The following is a description of a gene set: Human Gene Set: MORF_DDX11 Neighborhood of DDX11 species: Homo sapiens Neighborhood of DDX11 DEAD/H (Asp-Glu-Ala-Asp/His) box polypeptide 11 (CHL1-like helicase homolog, S. cerevisiae) in the MORF expression compendium, and this is the list of marker genes: IKBKG (NCBI Gene Id 8517), HTR4, ADAMTSL2, PAX8, PLIN3, IRF2BP1, TM4SF5, ALDOC, IRF2, SLC22A24, AMFR, CALCOCO1, F7, GALNT2, SLC12A4, NFRKB (NCBI Gene Id 94689), CSNK2A1, CLPX, HSF4, LSM12, PRSS16, SLC24A1, TEX28, ADAM15, IGSF9B, AQP5, EXTL3, SPTB, TCOF1, SLC30A3, DOK1, TTI1, ZNF592, CIZ1, TRA2A, NDST1 (NCBI Gene Id 3340), PMF1, PPIL2, PITPNM1, IGHMBP2, RBBP8, TNP1, SLC6A9 (NCBI Gene Id 6536), PCGF1, CAMK2B, BCL2, FANCG, HSPB2, FDXR, GHITM (growth hormone inducible transmembrane protein), MSX1, CDK13, RABGGTA, B4GALT3, SLC30A1, HNRNPL, TPR, TBCD, IMPA1, IFT140, WNT10B, ENTREP1, MCRS1, NUDT3, SETD1B, CASP2, GTF2H3, WDR62, EIF5B, MC2R, CSTF3, NFYB, PRPH, LSM1, DDX11, HTR7, RPA2, CDK5R1, TSPO2, CRYBA4, ACKR2, MYO9B, SIK3, ANKRD12, PKMYT1, ZNF500, ZKSCAN3, MT4, LTK, HMGXB3 (NCBI Gene Id 22993), PIGB, KYAT1, SSTR5, ENTREP3, MR1, GRIK5, BPHL, BAHD1, CLP1, CPSF4, TCF7, PTPN9, KLHL18, WWOX, HAUS5, CD8B, TNFRSF25, SLC5A2, SFSWAP, PVT1, EML3, AP3B1, CRHR2, RBM8A, DDB1, GPR35, MYL2, MTX1, PHB1, DPT, PML, CARD10, CRCP, MOK, CHD3, GCAT, KHNYN, SPEF1, NCKIPSD, CNTN2, KAT8, GRK4, SLC25A11, FKBP15, AGPAT1, USP19, MPP2, RASSF1, SLC2A1, HMG20B, CNP, SH2B1, DGCR11, RANBP2, KIFC3, PCBP3, ECE2, TMEM94, TLN2, PFDN1, BTD, MGAT1, PRKCSH, RPS6KB2, ARSL, NELFB